Given this list of marker genes PYCARD, IL1B, TLR4, CTSB, NFKB1, NOX1, CASP1, here is a description of the gene set: studied in species Homo sapiens Human Gene Set: WP_NANOMATERIALINDUCED_INFLAMMASOME_ACTIVATION Nanomaterial-induced inflammasome activation